The following is a description of a gene set: Human Gene Set: HP_ALOPECIA_OF_SCALP Alopecia of scalp studied in species Homo sapiens, and this is the list of marker genes: COL17A1, GTF2E2, KLHL24, SLC27A4, AARS1 (alanyl-tRNA synthetase 1), POLR3A, KRT74, LAMB3, TP63, ECM1, MPLKIP, SLC39A4, CLDN1, KDF1 (NCBI Gene Id 126695), RHOA, UROD, KRT14, MAP2K2, COL18A1, ERCC3, CARS1, PKP1, GJB6, TARS1, SASH1, GJB2, CDSN, GTF2H5, ERCC2, COL3A1, SLC29A3, RNF113A, TTC7A, PLEC, GATA1, EBP, WRN, UROS, HTRA1, ITGB4, LAMA3, MBTPS2, DCLRE1C, PI4KA, LAMC2